The following is a description of a gene set: species: Homo sapiens Human Gene Set: GOBP_DETOXIFICATION_OF_NITROGEN_COMPOUND Any process that reduces or removes the toxicity of nitrogenous compounds which are dangerous or toxic. This includes the aerobic conversion of toxic compounds to harmless substances., and this is the list of marker genes: GSTM3, MTARC1, GSTM1, GSTM2, MTARC2